Given this list of marker genes MMP14, GLI3, CX3CR1 (NCBI Gene Id 2836), VCAN, RELN, TSPO, CCR2 (NCBI Gene Id 90262), SUN1, AZU1, CERS2, MBOAT7, WDR47, CX3CL1, RRAS2, CDK5R1, GPR183, MIR222, RRAS, HEXB, CRKL, SRGAP2, APCDD1, EPHA4, NF1, CCL3, RTN4, BMERB1, DAB1, CCL2, FOXG1, MIR221, TREM2 (NCBI Gene Id 54209), ATP1B2, TGFB2, PAFAH1B1, DAB2IP, SCRIB, CSF1, PTPRB, ADGRG1, SOCS7, DISC1 (NCBI Gene Id 80138), SRGAP2C, P2RY1, ZMIZ1, LAMB1, CTNNB1, IDH2, STAP1, NDN, NTN1, CDK5R2, CD9, CDK5, MATN2, SYNE2, SUN2, CSPG4, COL3A1, LRP8, NR2E1, P2RY12, P2RX4, here is a description of the gene set: Human Gene Set: GOBP_GLIAL_CELL_MIGRATION The orderly movement of a glial cell, non-neuronal cells that provide support and nutrition, maintain homeostasis, form myelin, and participate in signal transmission in the nervous system. studied in species Homo sapiens